Given this list of marker genes Diablo, Gsdme, Gm10053, Casp3, Xiap, Septin4, Apip, Gsdmd (NCBI Gene Id 69146), Mapk3, Apaf1, Cycs, Casp9, Bax, Casp7, Bak1, Aven, Mapk1, here is a description of the gene set: Mouse Gene Set: REACTOME_APOPTOTIC_FACTOR_MEDIATED_RESPONSE species: Mus musculus Apoptotic factor-mediated response